The following is a description of a gene set: The vesicular release of gamma-aminobutyric acid (GABA). from a presynapse, across a chemical synapse, the subsequent activation of GABA receptors at the postsynapse of a target cell (neuron, muscle, or secretory cell) and the effects of this activation on the postsynaptic membrane potential and ionic composition of the postsynaptic cytosol. This process encompasses both spontaneous and evoked release of neurotransmitter and all parts of synaptic vesicle exocytosis. Evoked transmission starts with the arrival of an action potential at the presynapse. studied in species Mus musculus Mouse Gene Set: GOBP_SYNAPTIC_TRANSMISSION_GABAERGIC, and this is the list of marker genes: Gabra3, Gabrb3, Gabbr2, Car2, Npas4, Rac3, Slitrk3, Htr1b, Baiap3, Grik1, Tac1, Car7, Gabrg2, Gabbr1, Phf24, Oxtr, Plcl2, Nrxn1 (neurexin I), Gabrg1, Slc38a1 (NCBI Gene Id 105958), Clcn3, Hapln4, Adora1, Gabra4, Erbb4, Vps54, Nisch, Tpbg, Gabra1, Cacna1a, Tacr1, Npy5r, Drd2, Cnr1, Usp46, Nf1 (neurofibromin 1), Cln3, Kif5b, Gabra5, Cnr2 (cannabinoid receptor 2), Hap1, Adora2a, Best1, Gabra6, Kcnk2, Prkce, Drd4, Gabrb2, Clstn3, Gabrg3 (NCBI Gene Id 70716), Pak1, Cntnap4, Gabre, Nps, Plcl1, Ezh2, Zdhhc12, Stxbp1, Nalcn, Adra1a, Zdhhc3, Cntnap2, Pten, Gabrd (gamma-aminobutyric acid (GABA) A receptor, subunit delta), Nlgn2, Cacnb4, Gabra2, Dbi, Nlgn1, Slc6a1, Bdnf, Kras, Cckbr, Aldh5a1, Rac1